Given this list of marker genes E2F8, MDFI, NR2F2, GCM1, SPINT2, DNAJB6, PLG, STK4, ST14, PLK4, SOX15, HAND1, GRHL2, SENP2, STK3, CASP8, KRT19, EOMES, SNAI1, LIF, PRDM1, ELF5 (E74 like ETS transcription factor 5), GJB5 (gap junction protein beta 5), FZD5, KRT8 (keratin 8), E2F7, here is a description of the gene set: studied in species Homo sapiens The process in which a relatively unspecialized cell acquires specialized features of the embryonic placenta. Human Gene Set: GOBP_CELL_DIFFERENTIATION_INVOLVED_IN_EMBRYONIC_PLACENTA_DEVELOPMENT